The following is a description of a gene set: species: Homo sapiens Human Gene Set: GOBP_STRESS_GRANULE_DISASSEMBLY The disaggregation of a stress granule into its constituent protein and RNA parts., and this is the list of marker genes: VCP, FAF2, DYRK3, TRIM21, ZFAND1, KIF5B, KLC1